The following is a description of a gene set: Human Gene Set: GSE12392_IFNAR_KO_VS_IFNB_KO_CD8_NEG_SPLEEN_DC_UP Genes up-regulated in CD8A- splenic dendritic cells: IFNAR1 knockout versus IFNB1 knockout. Type I Interferons encompasses a large family of closely related cytokines comprising of at least 13 IFN-α isotypes and single IFN-β. Both IFN-α and IFN-β exert their activity through a common receptor IFNAR. Type I Interferons have broad regulatory effects and various subtypes of dendritic cells are influenced by this cytokines. In our study we asked question whether the low, constitutive levels of type I Interferons produced under steady state conditions are important for proper function of splenic conventional dendritic cells. species: Homo sapiens from publication Zietara N, Łyszkiewicz M, Gekara N, Puchałka J, Dos Santos VA, Hunt CR, Pandita TK, Lienenklaus S, Weiss S (PMID 19581626), and this is the list of marker genes: IVNS1ABP, KPNA4, PPIL3, CYTH1, LRRC40, PPP3CC, SAV1, TANK, MYPN, COCH, DCAF1, TBX19, MFGE8, ZC3H12C, RSRC2, ZNF136, EHD4, DNMT1, ZNF267, DDX21, MAP3K2, SDC4, CYP1B1, BFAR, WBP4, ZBTB1, ANKRD28, KDM3A, B3GAT2, FCHSD2, EPN3, KAT6A, PHF13, CLK3, DEPP1, CLDND1, TUBB2A, ERAP1, ID2, BRWD1, PER2, P2RX4, PPP4R2, ANKRD11, CORO1C, ARL5B (NCBI Gene Id 221079), ID2B, OSGIN2 (oxidative stress induced growth inhibitor family member 2), GNA13, PRNT, CREBRF, SEC24B, SLC38A2, BIRC3, SERTAD2, C1orf52, NFE2L2, ZNF627, B4GALT5, SNX5, SLC31A2, CHMP1B, LINC01128, AFG2B (NCBI Gene Id 80051), TMOD3, GOSR1, SERTAD3, WDR33, ZBTB46, ZMIZ1, DTX1, FRMD8, CYP51A1, HIVEP1, F3, PLAUR, CCNG2, KDM5C, MFSD14A, NCK1, LINC01532, MCMBP, EIF1, TRIM36, DUSP2, NPPC, FAM162A (family with sequence similarity 162 member A, NCBI Gene Id 26355), EHD1, PPIL4, KDM6B, PPIF, EIF5A, CDK17, ENO1, CNOT8, SGK1, TOB1, SRFBP1, PANK4, CNTLN, RRN3, RIF1, MLNR, CDC42, CYTIP, LGALS3, NDE1, TAGLN2, RGCC, PIM3, SPRR2C, SNX16, CDC42EP3, TNFRSF12A, NEK7, EWSR1, USP12, SEMA4C, GAS2L3, DNAJB9, LINC00847, R3HDM4, RAB5A, MED17, RAPGEF6, NDEL1, GPCPD1, GATA4, GFPT1, RPRM, RAPH1, CFLAR, ZC3H12A, DSCR10, IFNGR2, SERTAD1, CEP104, SLC16A6, EIF4A1, ZBTB21 (zinc finger and BTB domain containing 21), CDC73, PTGER4, RGS1, SLC16A3, ELL2, MAFF, DNTTIP1, ETV3, PEDS1, AKAP8L, CHST11, REL, KLHL28, PTX3, PPTC7, PDGFB, ICAM5, JUN, EPOP, ZDHHC20, MAPK8, BAG3, SDE2, ELF4, ZBTB10, RP2, PARP6, MAFK, SP5, GLIS2 (GLIS family zinc finger 2), NAA15, SNHG5, LINC01686, TSC22D3, SHB, STRN3, HLA-DPA1, CTXN1, ZNF277, CH25H, CSGALNACT2, AGFG1, SAMTOR, CLN8, CHKA, ZFAS1, AHRR, DUSP5, ATF3, UAP1, UBALD2, CCL4, BTG3, GPR35, DNAI1, MAP1LC3B (microtubule associated protein 1 light chain 3 beta), CTTNBP2NL, FGF3, LRP12